Given this list of marker genes Nusap1, Ipo5, Anp32b, Smc2, Zfp358, Coil, Ncaph2, Camp, Slc29a1, Racgap1, Ramp1, Il4, Casp3, Cdc20, Mmp14, Ccnb1, Gphn, Flii, Ccne1, Fam111a, Mki67, Melk, Cdkn1a, Bub1, Gsn, Cdc45, Cdca3, Tmpo, Crip2, Haus6, Cdkn3, Mthfd2, Stmn1, Nucks1, Aurkb, Ttk, Azin1, Tk1, Sgo1, Hells, Xpo1, Kin, Ccna2, Abr, Incenp, Lig1, H2ac6, Rfc5, Gm4870, E2f8, Dlgap5, Anp32a, Ckap5, Ddx19a, Pola1, Tuba3a, H2-Eb1, Nek2, Ncaph, Nedd4, Kifc5b, Kpna2, Rbl1, Htt, Hes1, Nt5dc2, Dnmt1 (DNA methyltransferase 1), Tuba1a, Ect2 (ect2 oncogene), Snx2, Ldha, Ccnb2, Pih1d1, Dbf4, Cks2, Kif23 (kinesin family member 23), Rad51, H2-Ab1, Tubb4b, Mcm6, Eif2ak2, Arl1, Nudc, Cdc25c, Mcm10, Ssx2ip, Jade1, Plk4, Kif2c, Rrm1, Myh11, Pck2, Rfc3, Acy1, Brca2, Dna2, Spdl1, Fen1, Ppp1ca, Anln (anillin, actin binding protein), Ctc1, Cdk1, Tuba1b, Aars1, Kif22, Hjurp, Actn4, Ube2c, Cit, Top2a, Ube2t, Trip13, Gm4739, Rad54l, Dctpp1, Cenpa, Prc1, Cenpl, Chaf1b, Stim1, Nasp, Cbx1, H2ax, Trim46, Eno1, Cdkn2c, Kif4, Ide, Tubb3, Cenpe, Hmgb3, Wdhd1, Rrm2, Kif20a, Itgb7, Ppp2ca, Vps72 (vacuolar protein sorting 72), Tubb5, Mis18bp1, Cbx5, Smc4, Cks1b, Rpa1, Anp32e, Cip2a, Myef2, Pclaf, Ube2s (NCBI Gene Id 77891), Psmc3, Cdca5, Hoxc5, Gspt1, Aurka, here is a description of the gene set: from publication Hoffmann R, Seidl T, Neeb M, Rolink A, Melchers F (PMID 11779835) Genes up-regulated during differentiation from large pre-BII to small pre-BII lymphocyte. Gene expression profiles of five consecutive stages of mouse B cell development were generated with high-density oligonucleotide arrays from as few as 2 x 10(4) ex vivo isolated and flow-cytometrically purified cells. Between 2.8% and 6.8% of all genes change on differentiation from one cellular stage to the next by at least twofold. The entire pathway involves differential expression of 10.7% of all genes. Previously known expression patterns of genes (like surrogate light chain, RAG-1/2, MHC class II, mel-14 antigen) are confirmed. The gene expression patterns of the proliferating pre-BI and large pre-BII cells on the one hand, and the resting immature and mature B cells on the other hand, are most similar to each other. Small pre-BII cells display a pattern that is transitional between these two groups. Most of the genes expressed in early precursors are involved in general processes, like protein folding or cell cycle regulation, whereas more mature precursors express genes involved in more specific molecular programs (cell surface receptors, secreted factors, and adhesion molecules, among others). Between 19 and genes share a given expression pattern. Combining knowledge about gene function and expression pattern allows identification of novel candidate genes potentially involved in self-maintenance of pre-BI cells, allelic exclusion and pre-B cell receptor signaling in large pre BII cells, cell-cycle arrest of small pre-BII cells, propensity toward apoptosis or anergization in immature B cells, propensity toward cell division and activation in mature B cells, and stage-specific interactions with stromal cells in the bone marrow. Mouse Gene Set: HOFFMANN_LARGE_TO_SMALL_PRE_BII_LYMPHOCYTE_UP species: Mus musculus